Given this list of marker genes Mef2c, Hey2 (NCBI Gene Id 30802), Smad6, Mdm4, Bmp4 (NCBI Gene Id 12159), Eln, Emilin1, Jag1, Naglu, Nos3, Bmp2, Robo2, Fam114a1, Fgfrl1, Gja5, Mdm2, Gata4, Adamts5, Slit3, Sox4, Olfm1, Axin2, Dchs1, Scx, Tbx20, Stra6, Ccn1, Bmpr2, Tgfbr2, Tbx5, Zfpm2, Notch1 (NCBI Gene Id 68125), Sox9, Rb1, Heyl (NCBI Gene Id 56198), Hey1, Dll4, Twist1, Smad4 (NCBI Gene Id 28063), Adamts9, Slit2, Gata3, Smad2, Tgfb2, Adamts19, Bmpr1a, Acvr1, Tgfb1, Robo1, Zfpm1, Rhoa, Notch2, Nfatc1, Gata5, Tie1, Efna1, Mtor, here is a description of the gene set: Mouse Gene Set: GOBP_HEART_VALVE_MORPHOGENESIS species: Mus musculus The process in which the structure of a heart valve is generated and organized.